Given this list of marker genes Slc2a13, Dhcr24, Epha4, Rtn1 (reticulon 1), Lyn, Psen1, Tmed10, Ifng, Adam19, Efna3, Adam17, Dyrk1a, Psen2, Sp1, Rtn3, Abca7, Flot2, Picalm, Apoe, Psenen, Adam10, Rela, Efna1 (ephrin A1), Csnk1e, Aph1b, Igf1, Rtn2, Ntrk2, Unc13a, Pin1rt1, Abca2, Tmed10-ps, Ranbp9, Chrna7, Bin1, Hap1, Abcg1, Gsap, Bace1, Gga3, Gsk3a, Lrrtm3, Spon1, Tnf, Aph1a, Rock1, App, Casp3, Rtn4, Aph1c, Ncstn, Prnp, Rps23rg1, Rock2, Ifngr1, Ager, Adam9, Clu, Pin1, Sorl1, Cln3, here is a description of the gene set: The chemical reactions and pathways resulting in the breakdown of amyloid precursor protein (APP), the precursor of amyloid-beta, a glycoprotein associated with Alzheimer's disease. species: Mus musculus Mouse Gene Set: GOBP_AMYLOID_PRECURSOR_PROTEIN_CATABOLIC_PROCESS